The following is a description of a gene set: Analysis of the transcriptional response to SARS-CoV-2 compared with other respiratory viruses, including MERS-CoV, SARS-CoV-1 (SARS), human parainfluenza virus 3 (HPIV3), respiratory syncytial virus (RSV), and IAV. from publication Blanco-Melo D, Nilsson-Payant BE, Liu WC, Uhl S, Hoagland D, Møller R, Jordan TX, Oishi K, Panis M, Sachs D, Wang TT, Schwartz RE, Lim JK, Albrecht RA, tenOever BR (PMID 32416070) species: Homo sapiens Human Gene Set: BLANCO_MELO_HUMAN_PARAINFLUENZA_VIRUS_3_INFECTION_A594_CELLS_UP Genes up-regulated in HPIV3 (A549 cells, MOI: 2, 24hpi), and this is the list of marker genes: ETV7, HCAR3 (NCBI Gene Id 91492), XAF1 (XIAP associated factor 1), CXCL10, CD38, IRF1, RGS2, EIF2AK2, GLCCI1, RUNX2, PPP1R15A, BTN3A3, IFITM3, IFIT2, TRIM14, LAMP3, CLTRN, ATF3, EPSTI1, LGALS17A, HERC6, UBE2L6, IFIT5, SLC15A3, TDRD7, IFITM1, CD68, MAP2, ZNFX1, IFI44, ZC3HAV1, CD274, SEMA3D, ZEB2, CFB, TRIM21, TRANK1, EFNB2, DTX3L, CTSS, IFNB1 (NCBI Gene Id 3456), FST, RAET1E, KLF4, OAS1, B2M, GBP5, TGM2, RIGI, THEMIS2 (NCBI Gene Id 9473), PLA1A, HLA-F, IFI44L, OASL, KLF6, PHLDA1, ERAP1, DUSP5 (dual specificity phosphatase 5), LIFR, TNFSF10, DDX60, CLMP, CORO2B, SIDT1, PLAAT2, CMPK2, MX2, PTX3, TRIM38, HSPA5, HYOU1, PHF11, TLR3, CARINH, IDO1, BTN3A1, SP110, XDH, PARP10, APOL1, CD55, LRRN3, RASGRF2, PPM1K, CH25H, IFNL1, HK2, STC1, ATP4A, CEACAM1, IFI16, EGR1, GBP3, SP140L, SAMD9L, NLRC5, IFIT3, PMAIP1, EPHA4, USP18, BMPER, TAP2, PARP14, TNFSF13B, DHX58, LAP3, PSMB8-AS1, GBP1, OTUD1, ERAP2, TMEM140, ALDH1L2, GLIPR1, HCP5, PARP12, TNFAIP3, PTGER4 (NCBI Gene Id 5734), SP100, SAMD9, LMO2, PRDM16, GMPR, JAK2, PODXL, CASP1 (caspase 1), NT5E, OAS3, IL1A, NIBAN1, IFIT1, ANXA10, DDX60L, TRIM25, RASGRP3, TRAF1, SERPING1, LAMC2, CCL3, APOL3, IFNL2, RET, RAET1L, CRYBG1 (NCBI Gene Id 6763), CXCL11, KIAA1549L, IL12A, TAP1, RTP4, NFE2L3, NOCT, DCLK1, FZD4, ULBP2, PNPT1, IFIH1, IL6, TRIM5, MXD1, RSAD2, MX1, BATF2, PLSCR1, PLAUR, PARP9, UBA7 (NCBI Gene Id 7875), HERC5, SAMHD1, BST2, CCBE1, IRF9, CREB5, EREG, OAS2, WARS1, GBP4, MCL1, MIR100HG, SHFL (NCBI Gene Id 55337), MCTP1, BIRC3, IL1B, APOL6, STAT1, CDCP1, HELZ2, NCF2, MYPN, IL15RA, RUFY4, CCL4, PLEKHA4, C1S, TNFAIP6, IFNL3, IL4I1, PIK3AP1, IRF7, ITGA2, HCAR2, STAT2, TRIM22 (tripartite motif containing 22), NMI, NT5C3A